The following is a description of a gene set: Genes down-regulated in CD4 T cells: untreated (0h) versus activated by anti-CD3 and anti-CD28 (48h). studied in species Homo sapiens from publication Lund R, Aittokallio T, Nevalainen O, Lahesmaa R (PMID 14607935) Th1 and Th2 cells arise from a common precursor cell in response to triggering through the TCR and cytokine receptors for IL-12 or IL-4. This leads to activation of complex signaling pathways, which are not known in detail. Disturbances in the balance between type 1 and type 2 responses can lead to certain immune-mediated diseases. Thus, it is important to understand how Th1 and Th2 cells are generated. To clarify the mechanisms as to how IL-12 and IL-4 induce Th1 and Th2 differentiation and how TGF-beta can inhibit this process, we have used oligonucleotide arrays to examine the early polarization of Th1 and Th2 cells in the presence and absence of TGF-beta after 0, 2, 6 and 48 hours of polarization. Human Gene Set: GSE2770_UNTREATED_VS_ACT_CD4_TCELL_48H_DN, and this is the list of marker genes: CMPK2, ATF3, DTHD1, KIF13B, CYB5R1, AP5Z1, ZNF322, HDAC4, NEIL1 (nei like DNA glycosylase 1), ZNF621, RASD1, ZNF776, IFIT2, PBOV1, SLC39A10, CLIC6, GFI1, ENTPD6, SHROOM3, ALDH8A1, CSNK1E, C6orf89, IFITM1, CDX4, RGS3, PDE8A, SOS2, CCL20, ZEB1-AS1, TBC1D13, ZNF282, KLF7, ISG15, C6orf226, ZNF439, LINC00526, ETV6, CYSLTR1, GPR68, ZNF852, RPP25L, NRBP2, CAPG, N4BP2L1, TYRP1, STK17A, TMEM116, AACS, ZNF419, NIFK-AS1, FHOD3, IRF2BP1, LYST, GREM2, ZNF7, BCL2A1, ANKRA2 (ankyrin repeat family A member 2, NCBI Gene Id 57763), PAXIP1-DT, DNAJB2, ZNF561, STOM, ADCY6, C2orf92, PDE3B, TSTD2, ZFP90, SPI1, NTNG2, PHYH, AMIGO2 (adhesion molecule with Ig like domain 2), RBBP9, TUB, SOCS1, MAGEE1, VRK3, RNF169, C10orf143, INSC, PHLDA1, ZNF420, JUN, MSL2, ITPKB, ENSG00000272447, CNTN3, STX1A (syntaxin 1A), PDE4D, ZSWIM6, RUBCN (NCBI Gene Id 9711), PSTPIP1, RTL8C, MLXIP, MACROH2A2, CD6, KIZ, RNF32-DT, NOTCH2NLA, GALNT6, MAN2C1, ZNF709, ZNF791, DSTYK, MIR124-1HG, TTC32, LINC00623, TNFSF12, ANK3, ADAM8, RAP1A, LINC01097, SNTB1, TNFSF4, LINC01588, INPP5A, ZNF8, CABLES1, DZIP1, P4HA2, GALM, DCUN1D3, LYRM1, TSPOAP1, LYRM9, SCARNA17, RUFY3, LAG3, ZBED5-AS1, IRAK2, ZNF251, ZNF562, ZNF846, VEGFA, CSRNP1, STAT3, RNF144A, SALL3, ZNF563, ZNF79, EXOC3-AS1, EGR1, FBXO46, S1PR3, IGSF9, DNAJC4, WASH3P, SHISA5, ZNF222, AGA-DT, MOCOS, PTPRO, OTUB2, ZNF558, ARFIP1, RSAD2, GARRE1, FBXO41, ZNF571, HERC2P3, TIMP1, TOR1B, TCF25, ZNF880, TSPAN31, LAMA5, NBPF1, ZNF493, GNA12, CD96, TMEM8B, BCL6, NFE2L1, MTHFR, COG1, ASCC1 (NCBI Gene Id 51008), PLAC8, CTSL, ZNF266, NRN1, ZNF573, CMTM1, CYTH3, RASA2, MIB2, FAM76A, CD72, TNFSF15, ULBP2, NR1I2, MOSMO, PRR23E (PRR23 family member E), IL6ST-DT, PARP11, C6orf52, PCYOX1, CSTF2T, ZNRF3